Given this list of marker genes Sox4, Sgk1, Lox, Shox2, Fam3c, Dusp16, Ifit1, Dpt, Irf9, Irgm2, Prl2c3, Angptl2, Ccnd2, Tgfbi, Ifi27l2a, Gbp3, Cxcl10, Ccn1, Gm9706, Impact, Tnk2, Igtp, Man2a1, Foxp1, Zeb1, Jun (jun proto-oncogene), Isg15, Efnb2, Plekho1, Il1rl1, Dusp1, Prl2c2, Tnc, Ctnnd2, Usp18, Ifit3, Ccl5, Runx1, Cd276, here is a description of the gene set: Mouse Gene Set: HAN_JNK_SINGALING_UP from publication Han SY, Kim SH, Heasley LE (PMID 12354774) The c-Jun N-terminal kinases (JNKs) are encoded by three genes that yield 10 isoforms through alternative mRNA splicing. The roles of each JNK isoform in the many putative biological responses where the JNK pathway is activated are still unclear. To examine the cellular responses mediated by different JNK isoforms, gain-of-function JNK1 polypeptides were generated by fusing the upstream mitogen-activated protein kinase kinase, MKK7, with p46JNK1alpha or p46JNK1beta. The MKK7-JNK fusion proteins, which exhibited constitutive activity in 293T cells, were stably expressed in Swiss 3T3 fibroblasts using retrovirus-mediated gene transfer. Swiss 3T3 cells expressing either of the MKK7-JNK polypeptides were equally sensitized to induction of cell death following serum withdrawal. To search for other cellular responses that may be selectively regulated by the JNK1 isoforms, the gene expression profiles of Swiss 3T3 cells expressing MKK7-JNK1alpha or MKK7-JNK1beta were compared with empty vector-transfected control cells. Affymetrix Genechips identified genes for which expression was increased in MKK7-JNK-expressing cells relative to vector control cells. Twenty genes including those for c-Jun, MKP-7, interluekin-1 receptor family member ST2L/ST2, and c-Jun-binding protein were induced similarly by MKK7-JNK1alpha and MKK7-JNK1beta proteins, whereas genes were selectively increased by MKK7-JNK1alpha and genes were selectively increased by MKK7-JNK1beta. The set of genes selectively induced by MKK7-JNK1beta included a number of known interferon-stimulated genes (ISG12, ISG15, IGTP, and GTPI). Consistent with these gene expression changes, Swiss 3T3 cells expressing MKK7-JNK1beta exhibited increased resistance to vesicular stomatitis virus-induced cell death. These findings reveal evidence for JNK isoform-selective gene regulation and support a role for distinct JNK isoforms in specific cellular responses. studied in species Mus musculus Genes up-regulated in 3T3 cells (fibroblast) upon activation of JNK pathway.